Given this list of marker genes Atp1a3, Ptpn11, Ppp1r1b, Cav2, Drd3, Snx5, Gnas, Arrb2, Ptger1, Nsf, Vps35, Dlg4, Grk3, Agtr1a, here is a description of the gene set: studied in species Mus musculus Binding to a D1 dopamine receptor. Mouse Gene Set: GOMF_D1_DOPAMINE_RECEPTOR_BINDING